The following is a description of a gene set: Human Gene Set: KEGG_MEDICUS_REFERENCE_ORGANIZATION_OF_THE_INNER_KINETOCHORE Organization of the inner kinetochore. Pathway ID: N01525. Pathway type: Reference. Pathway class: nt06515 Regulation of kinetochore-microtubule interactions. Pathway Definition from KEGG: CENPA == CENPC == CENP-LN+CENP-HIKM+CENP-OPQUR == CENP-TWSX species: Homo sapiens, and this is the list of marker genes: CENPQ, CENPA, CENPS, CENPK, CENPL, ITGB3BP, CENPW, CENPT, CENPM (centromere protein M), CENPU, CENPO, CENPP, CENPX, CENPC, CENPN, CENPI, CENPH